Given this list of marker genes Tgif1, Itgb8, Ephx1, Dnajb13, Cyp4f16, Cd244a, Arl5a, Ggt1, Ncmap, Il18r1, Galm, Psen2, Pear1, Gnaq, Scart1, Slc2a3, Fgl2, Cass4, Usp48, Cxcr6, Gpr34, Ptprj, Zfp608, Pou2f2, Dhx37, Il21, Camk2n1, 4930486L24Rik, Tgfbr3, Matk, Fhip1a, Tspan3, Crem, Atp6v0a1, Bco2, Themis, Id2, Sfi1, Ccrl2, Mtm1, Samsn1, Cd74, Rnf166, Khdc1a, Sorcs2, Igflr1, 2310015A10Rik, Slc15a2, Lamc1, Rnf144a, Igfbp4, Frmd5, Cela1, Klrg1, Baiap3, Tmbim1, Uap1, Prdm1, Dzip1 (DAZ interacting protein 1), Aldoc, Ehd3, Sp4, Itch, Malat1, Lyl1, Cybb, Serinc3, Ccr8, Acoxl, Acp3, Sema4a, Abca2, Irf5, Evi2a (ecotropic viral integration site 2a), Plxdc1, Tcf7, Ercc8, Cd47, Myo1f, Pglyrp1, Pkp4, Srsf2, Dgkd (diacylglycerol kinase, delta), Rnf216 (ring finger protein 216), Ms4a4c, Sptbn1, Ppm1l, Myo1e, Itsn1, Armcx4, Pde2a, Rhobtb1, Jak1, Pde3b, F13a1, Prdx6, Ky (kyphoscoliosis peptidase), Cbx7, Ctla2a, Rin2, Grb7, Oga, Ralgds, Naprt, Lgmn, Patl2, Prkch (protein kinase C, eta), Actg2, Bik, Entpd1, Bicd1, Atp6v0d2, Cc2d2a, Sox4, Sdc4, Itgb5, Pou2af1, Cdcp1, Fam234a, Dgat2, Gpr160, Rabgap1l, Casp3, Arhgef12, Cd80, Il10ra, C1qtnf6, Phxr4, Akap7 (NCBI Gene Id 54213), Clip1, Actr3b, Gpd2, Ptpn13, Pde7a, Gabarapl1, Mbp, Gjb2, Kat7, Cd200r1, Spock2, Slc35d1 (NCBI Gene Id 242585), Itgae (integrin alpha E, epithelial-associated), Epcam, Zfp983, Slfn1, Il18, S100a4, Hdac9, St14, Fcmr, Camk2b, Kctd12b, Sdr39u1, Slc22a5, Ptprv, Sytl2, Tdrp, Ms4a4b, Phlpp1, Fam81a, Usp18, Ikbip, Matn2, Alox8, Pnkd, St8sia1, Rapgef5, S100a6, Neo1, here is a description of the gene set: Regulatory CD4+ T cells (Tr cells), the development of which is critically dependent on X-linked transcription factor Foxp3 (forkhead box P3), prevent self-destructive immune responses. Despite its important role, molecular and functional features conferred by Foxp3 to Tr precursor cells remain unknown. It has been suggested that Foxp3 expression is required for both survival of Tr precursors as well as their inability to produce interleukin (IL)-2 and independently proliferate after T-cell-receptor engagement, raising the possibility that such 'anergy' and Tr suppressive capacity are intimately linked. Here we show, by dissociating Foxp3-dependent features from those induced by the signals preceding and promoting its expression in mice, that the latter signals include several functional and transcriptional hallmarks of Tr cells. Although its function is required for Tr cell suppressor activity, Foxp3 to a large extent amplifies and fixes pre-established molecular features of Tr cells, including anergy and dependence on paracrine IL-2. Furthermore, Foxp3 solidifies Tr cell lineage stability through modification of cell surface and signalling molecules, resulting in adaptation to the signals required to induce and maintain Tr cells. This adaptation includes Foxp3-dependent repression of cyclic nucleotide phosphodiesterase 3B, affecting genes responsible for Tr cell homeostasis. studied in species Mus musculus Mouse Gene Set: GAVIN_FOXP3_TARGETS_CLUSTER_P3 Cluster P3 of genes with similar expression profiles in peripheral T lymphocytes after FOXP3 loss of function (LOF). from publication Gavin MA, Rasmussen JP, Fontenot JD, Vasta V, Manganiello VC, Beavo JA, Rudensky AY (PMID 17220874)